Given this list of marker genes RIMS3, RIMS2, PCLO, ERC1, BSN, RAB3A, ERC2, RIMS1 (NCBI Gene Id 22999), here is a description of the gene set: studied in species Homo sapiens Human Gene Set: GOBP_MAINTENANCE_OF_PRESYNAPTIC_ACTIVE_ZONE_STRUCTURE A process which maintains the organization and the arrangement of proteins at the active zone to ensure the fusion and docking of vesicles and the release of neurotransmitters.